The following is a description of a gene set: studied in species Homo sapiens Human Gene Set: HP_SPOTTY_HYPERPIGMENTATION Spotty hyperpigmentation, and this is the list of marker genes: LYST, KRT5 (NCBI Gene Id 3852), FERMT1, KRT14, BANF1, PDE11A, CRIPT, SRD5A3, PRKAR1A